Given this list of marker genes Itpr1, F2r, Ehd1, Dmtn, Serpina5, here is a description of the gene set: A network of membrane-bounded compartments found in blood platelets, where they regulate platelet activation by sequestering or releasing calcium. The dense tubular network exists as thin elongated membranes in resting platelets, and undergoes a major ultrastructural change, to a rounded vesicular form, upon addition of thrombin. Mouse Gene Set: GOCC_PLATELET_DENSE_TUBULAR_NETWORK species: Mus musculus